Given this list of marker genes KIF3A, KIFAP3, FYCO1, MAPT, KIF5B, KIF13A, KIF3B, here is a description of the gene set: species: Homo sapiens Human Gene Set: GOBP_PLUS_END_DIRECTED_ORGANELLE_TRANSPORT_ALONG_MICROTUBULE The directed movement of an organelle towards the plus end of a microtubule, mediated by motor proteins. This process begins with the attachment of an organelle to a microtubule, and ends when the organelle reaches its final destination.